Given this list of marker genes Enpp1, Dctpp1, Dhx9, Itpa, Nudt1, Enpp3, Dut, Nudt16, Nudt15, here is a description of the gene set: species: Mus musculus Mouse Gene Set: GOMF_NUCLEOSIDE_TRIPHOSPHATE_DIPHOSPHATASE_ACTIVITY Catalysis of the reaction: a nucleoside triphosphate + H2O = a nucleotide + H+ + diphosphate.